Given this list of marker genes PKNOX1, AP1S2, ETNK1 (ethanolamine kinase 1), SHISA7, GEM, TM7SF3, ARHGEF26, ANXA6, RASSF8, RPGR, METTL9, KIF1C, ERGIC2, KCNK5, ARID3A, POC5, CBR3, CCDC91, CTSC, ACTR3, NTAN1, CLXN, PPP1R7, ABCC8, XCL1, SAR1A, SPA17, ADSL, EIF2B2, IL7R, MGP, ARHGEF2, RPA1, TMEM242, DNMBP, TCP11L1, here is a description of the gene set: DNA copy number alterations are believed to play a major role in the development and progression of human neoplasms. Although most of these genomic imbalances have been associated with dysregulation of individual genes, their large-scale transcriptional consequences remain unclear. Pancreatic carcinomas frequently display gene copy number variation of entire chromosomes as well as of chromosomal subregions. These changes range from homozygous deletions to high-level amplifications and are believed to constitute key genetic alterations in the cellular transformation of this tumor type. To investigate the transcriptional consequences of the most drastic genomic changes, that is, genomic amplifications, and to analyse the genome-wide transcriptional effects of DNA copy number changes, we performed expression profiling of 29 pancreatic carcinoma cell lines and compared the results with matching genomic profiling data. We show that a strong association between DNA copy numbers and mRNA expression levels is present in pancreatic cancer, and demonstrate that as much as 60% of the genes within highly amplified genomic regions display associated overexpression. Consequently, we identified 67 recurrently overexpressed genes located in seven precisely mapped commonly amplified regions. The presented findings indicate that more than one putative target gene may be of importance in most pancreatic cancer amplicons. Human Gene Set: HEIDENBLAD_AMPLICON_12P11_12_UP from publication Heidenblad M, Lindgren D, Veltman JA, Jonson T, Mahlamäki EH, Gorunova L, van Kessel AG, Schoenmakers EF, Höglund M (PMID 15688027) Up-regulated genes whose expression is associated with amplification of the 12p11-12 chromosome in pancreatic cancer cell lines. species: Homo sapiens